The following is a description of a gene set: Genes up-regulated in comparison of untreated CD4 T cells at 2 h versus the untreated cells at 72 h. from publication Elo LL, Järvenpää H, Tuomela S, Raghav S, Ahlfors H, Laurila K, Gupta B, Lund RJ, Tahvanainen J, Hawkins RD, Oresic M, Lähdesmäki H, Rasool O, Rao KV, Aittokallio T, Lahesmaa R (PMID 20620947) The aim of this dataset was to study in detail the transcription kinetics initiated by cytokine IL-4 in early differentiation of Th2 cells. Human Gene Set: GSE17974_2H_VS_72H_UNTREATED_IN_VITRO_CD4_TCELL_UP studied in species Homo sapiens, and this is the list of marker genes: METTL1, ALKBH8, DNLZ, SYNCRIP, ENSG00000272447, SRR, TCF25, TSSC4, ZNF416, CSRNP2, TMTC3, RAPGEF6, CLDN1, GADD45G, IL6, PLAA, SH2B3, NIPBL, GON4L, UTP15, FAM199X, RIN2, SRFBP1, ZNF542P, CXCL1, LTV1, LANCL2, FUBP3, ZNF804B, CIAPIN1, NIFK, OSTM1, TEX261, URB1, TNFSF8, RBM25, TMEM201, ACOD1, ZNF45, CCL20, ATP2B1-AS1 (ATP2B1 antisense RNA 1), SENP6, ZNF3, PUS3, QTRT2, GLIPR1, MRTO4, FAM133B, PLK2, MARS2, ESYT3, PON2, CMTR2, SURF2 (surfeit 2), NOL9, SNX9, DNAJC25, ZNF37BP, FAM3C, FAM177A1, AUTS2, SLC5A6, LYSET, ZNF682, DACH1, FAM169A, MAGIX, ZFP36, GABBR1, FYTTD1, HSPBAP1, CCNY, SMURF1, RYK, TRIM73, TRIM50, CTSO, ARFGEF2, KCNH8, TRMT61B, ARMC8, EGR2, GRAMD4, ASB6, EIF5, CYP20A1, TIMM23, SHISAL2A, CD83, PRNP, VEZF1, ATP8A1, ZZEF1, CHIC1, LRRC8D, RPP38, ZSWIM6 (zinc finger SWIM-type containing 6), SLC20A2, ZNF583, ENC1, FASLG, CORO7, DDX28, SGK3, FOS, TSPAN3, ZNF234, CRACR2A, CHD1, PHLDA1, PTX3, C6orf120, C12orf43, CXCL8, ST6GALNAC1, MICALL1 (NCBI Gene Id 85377), ZSCAN32, ZC3H8, CTSL, IL1B, ZNF268, RIPK1, ITPRIP, AGPAT4, FAM83G, LYPD3, ELK3, TRMT6 (tRNA methyltransferase 6 non-catalytic subunit), PLEKHO1, RBM18, NOL6, SAMD4B, DOP1A, SNAPC5, ATP6V0A2, KLF10, TNFSF14, SNRPN, UTP3 (UTP3 small subunit processome component), BCL2A1, ANXA1, ZNF223, BLOC1S4, RPP40, TMEM121B, HPS5, MTHFD2L, SMAD1, ELOA, FKRP (NCBI Gene Id 79147), POLR1A, TRMT13, NCKAP5L (NCBI Gene Id 57701), AP4E1, PLXNA1, ATP6V1G1, ZNF565 (zinc finger protein 565), DUSP5, MXD4, ARHGEF2, APOBEC1, FBXO21, MCRS1, GPA33, ZBTB49, DDX21, ZNF567, PIK3CA, TENT5A, PLXDC1, PLD6, LINC01138, USP27X, GZF1, APC, SGPL1, EGR3 (early growth response 3), BRIX1, IDI2, GCNA, TBL1X, SLC17A5, SLC25A25-AS1, LRP6 (NCBI Gene Id 4040), SNORD89, ZFP36L1, TRIM39, BACH1, UBE3C, LZTS3, SLC49A4, LYAR, ZNF131, MTUS2, PHF23, ZNF140, YRDC, C2orf42